Given this list of marker genes SRPX2, AHDC1, POMGNT1, ACP5, ERCC4, CRH (corticotropin releasing hormone), FBN1, COG1, BSCL2, GLB1, CRBN, SETD1B, HMGA2, NF1, EXT2, RBPJ, ANK3, ATP13A2, NFE2L2, GABBR2, POMT1, ZFX, ARPC4, SPG11, BBS10, ALX4, FIBP, SPEG, HEPACAM, HINT1, H19, SRY, HPD, RAP1B, SELENOI, DCDC2, SLC25A4, JAG1, TAC3, PEX11B, MTRFR, RAI1, SLC25A24, CTDP1, RNU4ATAC, TBC1D2B, POU3F4, SLC35A3, PAFAH1B1, CA8, MGP, FZD4, ABCC9 (ATP binding cassette subfamily C member 9), RECQL4, KCNC3, HPRT1, COG5, SOX3, MAN1B1, NGF, SPART, CPLX1, AASS, ARX, MYT1L (NCBI Gene Id 4662), GPAA1, RAD51, ACVR1, GRIA3, PDSS1, GRIN1, DMD, SCYL1, TRIO, PGAP2, NSDHL, DARS1 (aspartyl-tRNA synthetase 1), MLC1 (modulator of VRAC current 1), SKIC2 (SKI2 subunit of superkiller complex), KMT2D, CARS1, TBX1, HNRNPC, SLC25A36, DNAJC19, UPF3B, RAB3GAP2, NUP54, RSPRY1, PRPS1, ZC4H2, DYRK1A, SARDH, ATP2A2, SMS, BLM, ALAD, GLI3, EMC10, ACTB, DYM, METTL23, TAF4, JMJD1C, APC, TH, CENPJ, VPS13D, KDM6A, TKT, DNMT3A, KIF11, POU4F1, ADAR, SPRED2 (sprouty related EVH1 domain containing 2), DPYD, NDN, ERCC6, RREB1, UFD1, CDH11, CWF19L1, PNPLA2, OCA2, POMK, EYA1, SPTBN2, SCO2, RUBCN, KCNT1, NR4A2, NLGN4X, GP1BB, PHF8, TAF13, INPP5E, ACAT1, MECP2, ORC1, TBC1D7, EP300, TTC19, FMR1, MSMO1, DNAJC3, POLA1, PTEN (phosphatase and tensin homolog), CDK6, TMEM63C, NFIX, CDKL5, GALT, C12orf57, IGF2, FLNA, MARS1, GDI1, SOX11, NTN1, WAC, VPS16, GATA4, KLF13, CHD8, ARVCF, HEATR3, HSD17B4, PYCR1, FLCN, AFG3L2, LEMD3, SLC16A2, VRK1, PGAP1, NSD1, ATP6V0C, B4GALNT1, CTNNB1, ERCC8, SIN3A, PRMT7, ZNF408, AMER1, GORAB, NTRK1, BMPR1A, THOC2, CHRNA7, ADAMTS17, CSTB, DONSON, NKX2-1, MTHFD1, DLK1, POLR3A, SFXN4, MT-TL1, GMPPB, ACOX2, MSTO1, ADAMTS10 (NCBI Gene Id 81794), CHRNA2, CHRNB2, THG1L, SKIC3, CLCN4, AP1S2, MT-TL2, SDCCAG8, NTNG1, AKT1, ANO10, DNAJC21, MAP3K7, SRCAP, SIN3B (NCBI Gene Id 23309), TSPAN12, PRRT2, POMT2, WDR48, KIF1C, GBA2, PCDH19, BPTF, ZMYM2, SLC2A1, NDP, CSTF2, NARS2, MYCN, RARS1, ERMARD, ITPR1, PLP1 (proteolipid protein 1), TTN (titin), PCNA, UBE3A, TCF20, JAG2, DLAT, SLC29A3, MEG3, MARS2, ASCC3, INTS11, RPS6KA3, MIA3, SMC1A, TIMM8A (translocase of inner mitochondrial membrane 8A), DHX9 (NCBI Gene Id 3450), MT-ATP6, KMT2B, FGD1 (NCBI Gene Id 2245), DNAL4, SRRM2, AMFR, NUP62, MTSS2 (MTSS I-BAR domain containing 2), MED12, FGFR2, SCN8A, TBK1, MCM3AP, FREM1, MT-TN, BRF1, RCBTB1, MASP1, TBC1D24, ABCA2, FGF14, RTN4IP1, IFT140, TFAP2A, EIF2B4, HCN4, MAN2B1, PNPLA6, ZNF462, PSMB8, GLRA2, ALG1, POGZ, YY1, SUFU, CABP4, GTPBP3, GPSM2, STAC3, ZFR, FAT4, SRPK3, DEPDC5, GNE, NAGA, HIRA, ZMYND11, EXOSC2, GLIS3, TSPOAP1, EDC3, RYR1 (NCBI Gene Id 906), BRAF, KCNJ8, POLR3B, MECOM, PTPN11, SBDS, ADAMTSL2, LRP5, RAB39B (RAB39B, member RAS oncogene family), HDAC6, L1CAM, HMGCL, PIK3CA, KANSL1, CUL3, PEX10, TFAP2B, DSTYK, COMT, ARID1B, FOXP1, PITRM1, RAF1, CAMTA1, EZH2, SEC24C, BBS5, RTL1 (NCBI Gene Id 651665), PSMD12, MPV17, NONO, AP3B1 (NCBI Gene Id 8546), TRIM37, PIEZO2, MAGEL2, BRWD3, SLC12A6, CHRNA4, ZNF341, LTBP2, APC2, AGL (NCBI Gene Id 178), MID1 (midline 1), DNAJC12, CEP57, GRIK2, PIK3R1, RNF135, SRP54, PQBP1, SH2B1, IGF1, KCNQ1OT1, DCC, FKRP, WDR11, ATL1, AP5Z1, DAG1, BCOR, ATP9A, GNPTG, NAA60, ATP6AP1, SYN1, SHH, SLC18A2, BIN1, EIF4A2, SNRPN, here is a description of the gene set: studied in species Homo sapiens Human Gene Set: HP_INTELLECTUAL_DISABILITY_MILD Mild intellectual disability is defined as an intelligence quotient (IQ) in the range of 50-69. Intellectual disability, mild